Given this list of marker genes MYH10, MYH13, KIF13B, SPAG9, KIF24, WASH3P, SHROOM2, MACO1, RAB11B, KIF2A, MARK1, NEIL2, SPTA1, PACSIN1, FSD1, NEDD1, CALM1, STMN3, WDR90, TTLL9, ERMN, ANK3, CCDC170, SPAG5, HTT, MPRIP, SVIL, MYO3A, CHP1, ABRAXAS2, LSP1, FAM161A, EML1, HIP1, TRAK2, FABP3, CAP1 (cyclase associated actin cytoskeleton regulatory protein 1), ARPC1B, WASH6P, CLU, MAP1B, CEP135, MAP4K4, ABI1, ARL8B, SYT11, ANKRD35, APC2, TTLL7, PLEKHM2, RAB27A, CALM3, GAS2L2, PPP2CB, CORO2B, ARPC5, MTSS2, CTNNAL1, CNN1, PHACTR4, FLNB, MISP, STMN4, SETD3, NUF2, FERMT2 (NCBI Gene Id 10979), JAKMIP1, CAPN6, EML5, NRAP, TOR1AIP1, TULP1, ABRAXAS1, MARCKS, UXT, SYN1 (NCBI Gene Id 6853), COBLL1, PACSIN3, EML4, CCDC88C, MYL3, EP300, CDK5RAP2, CAPZA1, GJA1, MSRB1, FLNA, STARD9, ARPC1A, TNNC2, SBDS, SNTB2, MX2, MYO16, B4GALT1, DIAPH1, MYO1E, BCL2L11, TRIM36, DIAPH3, SHROOM3, OBSCN, TNNI1, MYH9, ADORA2A, KIF14, KNL1, LIMCH1, TBCC, VPS16, EML3, FYN, KLHL3, MAP7D3, MYH1, MYH7, TRPC5, MYO5B, FAM107A, PHACTR2 (NCBI Gene Id 9749), PXN, ABRA, VIL1, KIF21A, TAOK1, KIFC2, WDR1, MICAL1, MYO7A, SPATA6, CRYAB, LIMD2, FMR1, GCSAM, SPMIP6, DLGAP5, ARL3, NFKB1, P4HB, SLC6A4, DLEC1, CLIP4, APC, RELA, NUMA1, STAU2 (staufen double-stranded RNA binding protein 2), MARK3, SCN5A, FHDC1, RHCG, PRKN, ARL8A, CFL1, PPP5C, NCKIPSD, SPATA32, ABLIM2, TBC1D21, PHACTR3, CLMN, GAS2L3, KIF27, NOD2, TMOD2, PKNOX2 (NCBI Gene Id 63876), DIXDC1, DAG1, MYO1G, SSH2, KIF5A, NDE1, CAPZB, CREBBP, RARA, KCNE1, MYH14, SPTBN4, KLHL2, SKA3, CDK5R2, TLNRD1, TMOD1, CNN3, TPR, DUSP3, MAPRE2, CLIP3, CCDC181, ALDOC, HSPB7, MYL12B (NCBI Gene Id 103910), CORO6, PDE6G, MYOZ2, CCDC61, FNTA, KATNAL1, VPS18, SMTNL1, TUBGCP3, SAXO1, RAB29, TMSB10, KIF3C, MTUS2, PACSIN2, SPAG8, MYO6 (myosin VI), KIFC3, DST, TRIM63, ACTN3, LYN, MAST2, BIRC5, MYH7B, MYL2, SPACA9, AGBL5, CXCR4, CACNB2, TCAP, CAMK2D, NF2, RCC2, HDGF, ANG, MEFV, KIF9, CCDC69, FKBP4, CLIP2, DNAL1, BCCIP, MAP6, MARCKSL1, ACTR3, CEP44, CLSTN1, PICALM, BIN1, PICK1, VILL, MYLIP, CLIP1, SLC26A5, LRRC61 (leucine rich repeat containing 61), PAFAH1B1, GRIA1, LIN7C, TTLL4, CAP2, MAP1LC3B, DISC1, MYH4, MYOC, MYO5A, CETN3, CDC42EP3, SORBS1, FSCN1, RHOA, KPTN, HSPH1, CSRP3, KIFAP3 (NCBI Gene Id 22920), ACTN1, RAD51D, MICAL2, KLC4, MYH8, PDLIM3, ENKD1, EPS8L2, TOM1, APPL1, WASF3, PFN2, NPHS1, OPA1 (OPA1 mitochondrial dynamin like GTPase), GAS8, CACNA1D, TRAK1, TUBGCP6, MYO9B, KIF23, TAGLN2, HAUS8, NME8, EML6, PPP1R9A, NEFH, WASL, KRIT1, CEP57, DCLK2, TRPM7, CAPN10, MYO9A, MAP4, UTRN, GOLGA2, EPS8L3, TAGLN3, MYPN, INO80, TMEM67, MYO1F, CCSER2, UNC5C, IFT74, SMAD2, S100A8, DYRK1A, TPM4, CAPN2, TTLL2, TBCE, ANK2 (NCBI Gene Id 4028), KIF5B, RAB6B, FAM83D, NEBL, KLC1, AMOTL2, ANXA2, ARHGEF7, TOGARAM1, MAP6D1, GAS2L1, MAPT, GMFB, PSRC1, TRPV4, LGMN, DIP2B, REEP4, LARP6 (NCBI Gene Id 55323), GMFG, HNRNPU, RFLNB, KIF20A, BAG2, FTCD, MYO1A, KATNA1 (NCBI Gene Id 11104), TUBGCP4, PRKCE, DES, TOR1B, CCSAP, MYOZ3, FXYD5, KIF1B, PRNP, AJUBA, S100A4, RALA, TPPP2, SNTG1, KRT2, LLGL2, BRCA2, SLC6A2, RAB3D, MAPRE1, PDLIM5, MSN, ENC1, KLC3, SUN2, CACYBP, DBN1, DNASE1, EPS8L1, MICAL3, CAV3, TNNT3, ADNP, PPP2R2A, SNCA (NCBI Gene Id 6622), GSK3A, TWF2, CCDC187, REEP2, MYL4, POF1B, CD2AP (CD2 associated protein), SSH3, MAP10, CCT5, PTPN4, KCNN2, RACGAP1, MAGI1, IFT88, EPB41L5, DCDC1, SAMD14, FBXW11, NRCAM, FMNL1, PTPRC, TNNC1, KLHL4, TPM2, SMC3, RPH3AL, MTCL1, ANXA8, ACTB, MLPH, ACTN4, EFHC1, EGFR, DNM1, KIF26A, KNSTRN, TBCB, MYO15A, MX1, RP1, KIF16B, EPB41L4B, ESPN, BRCA1, BRSK2, PDE4B, ACTR3B, CCR5, MAP1A, SVBP, PARVA, RAB10, KIF7, EPB41L1, CLASP1, REEP1, CAPN3, CNGA3, CALML4, ARPC5L, PHPT1, HIP1R, DNM3, SYNPO2L, ABITRAM, EPB41, PARVB, LIMA1, MAP1LC3B2, CRMP1, SMAD4, RAB3C, DNAI7, FGF13, ANK1, PADI6, ATF5, SPATA6L, ARPC3, DSTN, RAB27B, HOOK2, ABL2, ROCK1, KIF2B, TPRN, MID1, VAPA, KLHL20, CCDC66, NCALD, SHANK3, ADSS1, SYNE1, RAB14, ACE, PLS1, PFN1, TTLL5, ARFGEF2, RAI14, JAKMIP2, RAB39B, GABARAPL1, CSRP2, MYH6, INF2, GAS2, CDH1, ACTN2 (NCBI Gene Id 88), CORO1A, PDLIM2, TERF1, ENAH, ROCK2, MIB2, SHROOM1 (shroom family member 1), CAMK2B, VEZT, PHACTR1, CCDC88A, IFT81, JMY, TLN2, RAB3B, CTNNA3, PKD2, MARK4, KIF4A, SYNPO (synaptopodin), PPP2CA, NDEL1, FRMD5, PARVG, MAPK8IP1, MYO1D (myosin ID), DPYSL4, KCNC1, RHAG, MYOZ1, LIMS1, STXBP5L, CFAP144, NPC1L1, SPAG6, HSP90AA1, SPTAN1, SSH1, ACTA1, TRIOBP, BCAS3, TMOD3, DCP1A, ITPRID2, AVIL, MAPK8IP3, FEZ1, PFN4, CENPF, MYLK, LMOD3, KIF21B, ALKBH4, TUBGCP2, CAPZA3, OGG1 (8-oxoguanine DNA glycosylase), MYRIP, PROM1, FLNC, MYO1C, HOMER2, DIAPH2, PDLIM7, NIN, ADD1, AFAP1, CEP295 (centrosomal protein 295), HOOK3, UACA, TTLL6, MAP1LC3A, TRIM32, POLB, FKBP15, HSP90AB1, CORO1B, EVL, MRTFA, ADD3, MAP9, SYNPO2, LLGL1, KIFC1, PRICKLE4, RABGAP1, KIRREL1, TNS1, HOOK1, SNTG2, PXK, AGTPBP1, CFAP157, MYBPC2, GIT1, NOS3, FERMT1, PACRG, ITGB1, IQGAP2, FHOD3, SPIRE2, CDK5R1, MYH2, MYL12A, ALDOB, MYBPC3, SPATA4, GBP1, TBCEL, TPPP3, ADD2, NAV3, TNS4, DLG1, KIF25, RAB25, NLRP5, SCIN, PHF6, CEACAM1, ANKRD23, PRKAA1, STRBP, KBTBD13, LMTK2, LRPPRC, HSPA2, ACTR3C, CLASP2, KIF17, RMDN2, HCLS1, PRUNE1, NEB, NEK6, RAB11FIP5, HAUS4, FMN1, LCP1, MARK2, TUBGCP5, ARL4C, MTUS1, BBS4, STMN2, MAP1S, KLHL17, HPCA, PPP1R42, CAPZA2, RMDN1, USH1G, GSN, MYO3B, RAB6A, TTLL13, MYO1H, PPP1R18, EZR (ezrin), KIF19, CETN1, PFN3, SAG, ANXA2P2, KATNAL2, GJB6, PLEKHG3, TOGARAM2, ABLIM3, RPS3, CNN2, MYH3, MYO5C, SAXO2 (NCBI Gene Id 283726), MYO18A, TAOK2, KIF2C, IMPACT, RUSC1, COTL1, FBXO25, ANTXR1, STXBP5, CAPG, MYOT, ARPC4, DCTN2, SMTN, CAMSAP1, NEXN, TPM1, AP1G1, PDLIM4, LRP8, SYNE2, GABARAP, SNTB1, PLEKHH2, BLOC1S2, CAMSAP3 (calmodulin regulated spectrin associated protein family member 3), STMN1, STX1A, SPEF1, WIPF3 (NCBI Gene Id 648464), BLOC1S6, RAB11A, WASF1, IQGAP3, DMTN, SNX5, MYBPC1, MYH15 (NCBI Gene Id 22989), KIF1A, TNNT2, KLHL5, MAP2, TLN1, KATNB1, NUSAP1, MID2, CEP290, NEFL, ANKRD24, RMDN3, ABL1, FARP1, KIF13A, PEX14, BICD1, WAS, RITA1, MAPK8IP2, RAE1, CTNNA1, MTSS1, WIPF1 (WAS/WASL interacting protein family member 1), VPS41, BEX4, CDK5, MYO18B, CTNNA2, TMSB15B, CIMAP3 (ciliary microtubule associated protein 3), TTN, IPP, HAUS7, PLK1, PAWR, PPARG, JAKMIP3, DYNC1I1, TOR1A, CRK, WHAMM, VCL, IQGAP1, SORBS3, KIF18B, CROCC, SKA2, MYO19, MYL9, ANLN, DLG5, KLC2, BRSK1, CEP57L1, XIRP1, FMNL3, NDN, SHROOM4, S100A9, EMD, USH1C, CEP70, PTK2, ACTC1, ALDOA, PIN1, EPS8, PTPN3, FSCN3, PLS3, NEFM, KIF18A, EPB41L2, TTBK2, PIP, TWF1, BCL7B, FMN2, GNB3, FBLIM1, TBCA, KIF15, CENPJ, TRIM54, DPYSL3, VASH2, TMSB15A, RGS2, ESPNL, YWHAH, DMD, PDCD5, CFL2, EEF2, MED28 (mediator complex subunit 28), TPM3 (NCBI Gene Id 91191), CETN2, SKA1, S100A6, KIF6, SYNM, NDRG1, CRIPT, MAPRE3, CENPE, TPPP, AGBL4, WIPF2, ARHGEF10, PAK1, CKAP5, SNTA1, HAP1, GC, KIF1C, CALM2 (calmodulin 2, NCBI Gene Id 805), RCSD1, ATCAY, MSRB2, TMSB4X, AP1AR, VBP1, HDAC6, CORO7, DCDC2, MYO7B, RUFY4, SPTBN5, SPC24, CEP350, PPP1R9B, CALD1, ARHGAP27, KIF3B, TMSB4Y, DNM2, KCNA2, KCNA5, LDB3, AGBL1, GIPC1, REEP3, GLI1, BAIAP2L1, FHL3 (four and a half LIM domains 3), XIRP2, ANKRD1, CORO2A, ABI3, ARPC2, WASF2, EML2, ARHGEF2, AFDN, PTPRN, LRRC10, MYH11, KIF5C, FRMD3, MYLK2, GSK3B, AIF1, CCDC88B, ADCY8, STUB1, DCTN1 (dynactin subunit 1), FLII, FES, FSCN2, MAEA, PKD2L1, KIF12, OFD1, CAMSAP2, SYNE3, ABLIM1, PANX1, MYO1B, MDM1, RAB8A, SLC8A1, BMP10, VASP, AGBL3, RANBP10 (NCBI Gene Id 57610), TNNI3, KCTD6, SPIRE1, FGD4, KCNMA1, USH2A, KIF20B, COBL (cordon-bleu WH2 repeat protein), ACTR2, KIF28P, TMOD4, KIF26B, GABARAPL2, PALLD, DNM1L, CYFIP1, TRAF3IP1, TTLL11, VASH1 (vasohibin 1), PRC1 (NCBI Gene Id 9055), EPB41L3, TMEM201 (NCBI Gene Id 199953), APOE, MAST1, PTPRT, FAM110C, TNNT1, AGBL2, B9D2, SPAST, CGN, IRAG2, GTSE1, RTCB, TBCD, WASHC1, RUFY3, KIF22, MAP7D2, DRG1, RFLNA, KIF4B, DBNL, PLEC, INPPL1, FMNL2, ZNF207, TNNI2, SGIP1, RGS14, FARP2, STIM1, SPTBN2, TRAPPC14, GAPDH, HAUS6, KCNJ11, SSNA1, LASP1, TRPC6, RHBG, ARFGEF1 (ADP ribosylation factor guanine nucleotide exchange factor 1), KCNQ2, MYO10, OPHN1, MACF1, BICDL1, SHTN1, MICALL2, KIF3A, DCX, SPTBN1, KTN1, EPB41L4A, SLC4A1, CACNA1C, TMSB15C, FRG1, NDC80, AIF1L, PDLIM1, CORO1C (coronin 1C), CSRP1 (cysteine and glycine rich protein 1), KIFBP, FHOD1, PYCARD, HDGFL3, KIF11, DAAM2, SPTB, DDX3X, LRRK2, KLHL1, KATNBL1, TPGS1, S100B, RCAN3, STK38L (NCBI Gene Id 23012), VAPB, SETD2, LUZP1, LMOD2, TAGLN (NCBI Gene Id 6876), RDX, SNX6, TTLL1, DAAM1, BICD2, TTBK1, NKD2, RAB3A, LMOD1, here is a description of the gene set: species: Homo sapiens Binding to a protein component of a cytoskeleton (actin, microtubule, or intermediate filament cytoskeleton). Human Gene Set: GOMF_CYTOSKELETAL_PROTEIN_BINDING